Given this list of marker genes Eng, Tshz3, Pias1, Pdcd4, Cth, Tmsb4x, Fgf9, Ankrd17 (NCBI Gene Id 81702), Bmp4, Tgfb1, Rbpms2, Notch2, Med28, Kit, Notch4, Shh, Sod2, Zeb1, Hey1, Olfm2, Rcan1, Prdm6, Mecp2, Dnmt1, Nfatc3, Nfatc2, Hey2, Myocd, Notch1, Pdgfb, Efemp2, Foxo4, Fgfr2, Gper1, Ereg, Nfatc1, Smarcd3, Sirt1, here is a description of the gene set: studied in species Mus musculus Mouse Gene Set: GOBP_REGULATION_OF_SMOOTH_MUSCLE_CELL_DIFFERENTIATION Any process that modulates the frequency, rate or extent of smooth muscle cell differentiation.